Given this list of marker genes Ninj1, Mir7b, Mir204, Wnk3, Oxsr1, Mir100, Mir29b-1, Mir451a, Mir9-1, Micu1, Mir137, Mir9-2, Wnk1, Xrcc5, Rcsd1, Pck1, Ybx3, Stk39, Slc25a23, Mir99a, Aqp1, Mir9-3 (microRNA 9-3), Mir29c, Abcb1a, Xrcc6, Mir29b-2, Letm1, Mir434, Slc2a1, Efhd1, Akr1b1, Mir30b, Fbp1, Epo, here is a description of the gene set: Mouse Gene Set: GOBP_CELLULAR_HYPEROSMOTIC_RESPONSE species: Mus musculus Any process that results in a change in state or activity of a cell (in terms of movement, secretion, enzyme production, gene expression, etc.) as a result of detection of, or exposure to, a hyperosmotic environment, i.e. an environment with a higher concentration of solutes than the organism or cell.